Given this list of marker genes PTPN2, CES1, NFKBIA, ITGB3, ABCA1, NR1H2, ABCG1, MIR146A, PPARA, TNF, ABHD5, PPARD, LEP, PNPLA2 (patatin like phospholipase domain containing 2), TTC39B, ITGAV (integrin subunit alpha V), NR1H3, CRP, PPARG, IL6, TREM2, CLSTN3, here is a description of the gene set: studied in species Homo sapiens Any process that decreases the rate, frequency or extent of lipid storage. Lipid storage is the accumulation and maintenance in cells or tissues of lipids, compounds soluble in organic solvents but insoluble or sparingly soluble in aqueous solvents. Lipid reserves can be accumulated during early developmental stages for mobilization and utilization at later stages of development. Human Gene Set: GOBP_NEGATIVE_REGULATION_OF_LIPID_STORAGE